Given this list of marker genes Wnt9b, Nipbl, Wnt7a, Ash1l, Stra6, Kdm5b, here is a description of the gene set: Mouse Gene Set: GOBP_UTERUS_MORPHOGENESIS species: Mus musculus The process in which anatomical structures of the uterus are generated and organized.